Given this list of marker genes RPS27A, MKNK1, FGF4, PLCG1, SRC, FGF17, SPRY2, PTPN11, FRS3, UBA52, CBL, FGFR3, MAPK3, GRB2, PPP2R1A, PPP2CA, FGF16, FGF1, FGF2, FGF9, SHC1, BRAF, PIK3R1 (NCBI Gene Id 5295), FGF5, PIK3CA, FGF18, SOS1, UBB, FGF8, PPP2CB, MAPK1, FRS2, FGF20, KRAS, GALNT3, NRAS, UBC, GAB1, HRAS, FGF23, here is a description of the gene set: species: Homo sapiens part of: Signaling by FGFR Reactome Pathway: Signaling by FGFR3 The 22 members of the fibroblast growth factor (FGF) family of growth factors mediate their cellular responses by binding to and activating the different isoforms encoded by the four receptor tyrosine kinases (RTKs) designated FGFR1, FGFR2, FGFR3 and FGFR4. These receptors are key regulators of several developmental processes in which cell fate and differentiation to various tissue lineages are determined. Unlike other growth factors, FGFs act in concert with heparin or heparan sulfate proteoglycan (HSPG) to activate FGFRs and to induce the pleiotropic responses that lead to the variety of cellular responses induced by this large family of growth factors. An alternative, FGF-independent, source of FGFR activation originates from the interaction with cell adhesion molecules, typically in the context of interactions on neural cell membranes and is crucial for neuronal survival and development.<br><br>Upon ligand binding, receptor dimers are formed and their intrinsic tyrosine kinase is activated causing phosphorylation of multiple tyrosine residues on the receptors. These then serve as docking sites for the recruitment of SH2 (src homology-2) or PTB (phosphotyrosine binding) domains of adaptors, docking proteins or signaling enzymes. Signaling complexes are assembled and recruited to the active receptors resulting in a cascade of phosphorylation events.<br><br>This leads to stimulation of intracellular signaling pathways that control cell proliferation, cell differentiation, cell migration, cell survival and cell shape, depending on the cell type or stage of maturation.<br>